Given this list of marker genes SLC7A5, SLCO1C1, SLCO3A1, SLC16A2, SLC16A10 (NCBI Gene Id 55457), SLC7A8, SLCO1A2, SLCO4A1, here is a description of the gene set: Human Gene Set: WP_PERTURBED_THYROID_HORMONE_HOMEOSTASIS_LEADING_TO_DEVELOPMENTAL_NEUROTOXICITY Perturbed thyroid hormone homeostasis leading to developmental neurotoxicity species: Homo sapiens